The following is a description of a gene set: Wax and plasmalogen biosynthesis species: Homo sapiens Human Gene Set: REACTOME_WAX_AND_PLASMALOGEN_BIOSYNTHESIS, and this is the list of marker genes: AWAT1, DHRS7B, AGPS, GNPAT, AWAT2, FAR1, FAR2